Given this list of marker genes Sacs, Ifnb1, Dnajb6, Hspa2, Dnajb1, Hsf1, Dnajb2, Sorl1, Dnaja4, Dnajb8, Hspa1b, here is a description of the gene set: Mouse Gene Set: GOBP_NEGATIVE_REGULATION_OF_INCLUSION_BODY_ASSEMBLY studied in species Mus musculus Any process that decreases the rate, frequency, or extent of inclusion body assembly. Inclusion body assembly is the aggregation, arrangement and bonding together of a set of components to form an inclusion body.